Given this list of marker genes RAN, MYBBP1A, SNUPN, KPNA2, KPNA1, KPNA7, KPNA5, KPNA4, KPNB1, KPNA3, KPNA6, XPO5, here is a description of the gene set: studied in species Homo sapiens Any complex that acts to move proteins or RNAs into or out of the nucleus through nuclear pores. Human Gene Set: GOCC_NUCLEOCYTOPLASMIC_TRANSPORT_COMPLEX